The following is a description of a gene set: studied in species Homo sapiens Human Gene Set: FAELT_B_CLL_WITH_VH_REARRANGEMENTS_DN from publication Fält S, Merup M, Tobin G, Thunberg U, Gahrton G, Rosenquist R, Wennborg A (PMID 15817677) The usage of the immunoglobulin (Ig) V(H)3-21 gene is associated with poor prognosis in B-cell chronic lymphocytic leukemia (B-CLL) despite V(H) gene mutation status. Many V(H)3-21+ patients also display restricted heavy- and light-chain Ig gene rearrangements, implying a role of antigen selection in disease development. To explore the specific phenotypic/genotypic features among V(H)3-21+ B-CLLs, we compared gene expression patterns in 15 V(H)3-21+ and 24 non-V(H)3-21 patients (11 with unmutated and 13 with mutated V(H) genes) using Affymetrix microarray analysis (approximately genes). A distinct expression profile was identified for V(H)3-21+ patients in contrast to the Ig-unmutated and -mutated groups. By applying different algorithms, the data enabled an efficient class discrimination of the V(H)3-21+ subset based on 27 or genes. A set of genes was sorted out which, using different analytical methods, consistently gave a distinction between V(H)3-21+ and non-V(H)3-21 samples. Several of these genes are involved in regulation of DNA replication/cell-cycle control, transcription and protein kinase activity, which may render the V(H)3-21+ cells with a higher proliferative drive. However, no clear evidence of increased B-cell receptor signaling was found in the V(H)3-21+ group. Altogether, our identification of a specific V(H)3-21 profile may provide insights into the pathogenesis of the V(H)3-21+ subgroup. Genes down-regulated in B-CLL (B-cell chronic lymphocytic leukemia) patients with mutated immunoglobulin variable heavy chain (VH) genes., and this is the list of marker genes: XPO1, DDX1, PRPS1, ADTRP, TRAPPC8, TMX4, ASMTL, CBX7, PSMD8, DCTN3, GTF3A, KRT10, ZMYND11, MAGED2, JARID2, LDOC1 (NCBI Gene Id 93489), HNRNPU, NDUFC1, YWHAQ (NCBI Gene Id 10971), EID1, DEFA1, SOD1, VPS13B, DDX19A, CDK14, MRPL40, PLCL2, SLC35D2, TGOLN2, PFKP, TMEM147, XBP1, MOAP1, PBX3, HSPA4, FKBP1B, UBE2D2, TMED10, YY1, MYLK, LYRM1, PPP1R2, GLO1, PFN2, SELENOF, TSPYL4, ZHX2, ATP6V1G1, PARP4